Given this list of marker genes BCAN, HCFC1R1, ACTA2, IGHM, TGM2, LDB3, MYH1, CXCL10, RUSC2, PAN2, PYGM, MIR22HG, MYH3, XRCC4, CRYAB, FHL1, SGCG, HLA-A, TNNI1, PBXIP1 (PBX homeobox interacting protein 1), AQP6, TPM1, AGL, FAM131B, APOBEC2, CDC42EP2, PDE4DIP, UTRN, RANBP3, ADAM30, ENSG00000279328, AMPD1, INPP4B, MYOM1, CTF1, MYBPH, PNOC, COL6A3, ABLIM3, SPDEF, SLC12A2, PRRX2 (NCBI Gene Id 51450), PDLIM5, MAPRE3, MYL4, CYP2W1, HSPB2, HBEGF, ATF7IP2, CLSTN2, ADAP1, SRGAP3, EPCIP, ARSF, RBM8A, NCAM1, EPS8L1, SCD, CAVIN1, MYBPC1, DOK1, ITGA6, GRIN1, MYBPC2, DNAJC7 (NCBI Gene Id 7266), CD36, ADAM8, ASCC1, SCN3B, GPR37, DCN, TNS1, EZR, MEF2C, PRKCQ, CASQ2, DPAGT1, BBS9, TNNT3, ATP2C2, ACSL1, CX3CL1 (C-X3-C motif chemokine ligand 1), ACTBP9, TNNC2, PLEK, IGFBP4, SLC24A1, KLF6, C1R, MYL11, RGS2, LAT2, FABP3, VARS1, ATP6V0A4, AK1, SFSWAP, ACAA2, CCR5, ARMC9, MEF2D, SST, EPB41L3, MRAS, TP63, GNAO1, CACNB1, MYL1, BORCS8 (BLOC-1 related complex subunit 8), LRTM1, DMPK, CHODL, TRAC, DCX, TNPO2, ACHE, ANKZF1, DES, MACF1, RSPH6A, MYO10, EFS, AHNAK2, RANBP1, GHRHR, SGCD, NOX1, AKAP1, ITGB1BP2, QKI, TNNI2, KLF1, TNNC1, TNFAIP2, ING4, PARP3, MYL6B, MYH8, RPL22P22, EHBP1L1, GSTA1, FER, BICD1, PLA2G3 (phospholipase A2 group III), TRAF5, RPL21P2, MTSS1, CELA3B, GNAI2 (NCBI Gene Id 2771), COL1A1, FYB1, FOSL2, TAOK2, GPRIN2, HSPB3, LIF, SYNGR2, RASSF4 (Ras association domain family member 4), CAMK2B (calcium/calmodulin dependent protein kinase II beta), REEP1, GMEB1, FAM13A, HBA1, SELENOW, ARHGEF6, MUC3A (NCBI Gene Id 732156), IRGQ, HIVEP3, SERPINB1 (NCBI Gene Id 1992), AEBP1, CASP10, TAGLN, ALDH1A2, TTC3, P3H4, GJB1, GADD45B, C2CD2L, ISG15, TXNIP, CALCRL, STK10, COL16A1, TEAD4, MAPK7, HRH1, BIN1, RARB, SOHLH2, NEBL, SLN, SPAG6 (NCBI Gene Id 9576), IL32, SMPX, PALMD, WWTR1, TUBAL3, TPD52L1, EGLN3, ACBD4, here is a description of the gene set: Human Gene Set: EBAUER_TARGETS_OF_PAX3_FOXO1_FUSION_UP Genes up-regulated in Rh4 cells (alveolar rhabdomyosarcoma, ARMS) after knockdown of the PAX3-FOXO1 fusion protein by RNAi for 72 hr. species: Homo sapiens The chromosomal translocation t(2;13), characteristic for the aggressive childhood cancer alveolar rhabdomyosarcoma (aRMS), generates the chimeric transcription factor PAX3/FKHR with a well known oncogenic role. However, the molecular mechanisms mediating essential pathophysiological functions remain poorly defined. Here, we used comparative expression profiling of PAX3/FKHR silencing in vitro and PAX3/FKHR-specific gene signatures in vivo to identify physiologically important target genes. Hereby, 51 activated genes, both novel and known, were identified. We also found repression of skeletal muscle-specific genes suggesting that PAX3/FKHR blocks further differentiation of aRMS cells. Importantly, TFAP2B was validated as direct target gene mediating the anti-apoptotic function of PAX3/FKHR. Hence, we developed a pathophysiologically relevant transcriptional profile of PAX3/FKHR and identified a critical target gene for aRMS development. from publication Ebauer M, Wachtel M, Niggli FK, Schäfer BW (PMID 17525748)